The following is a description of a gene set: studied in species Homo sapiens Genes down-regulated in monocyte-derived dendritic cells: untreated versus LPS like antigen from O. planktothrix (1h). A cyanobacterial LPS antagonist prevents endotoxin shock and blocks sustained TLR4 stimulation required for cytokine expression. We report the identification and biologic characterization of an LPS-like molecule extracted from the cyanobacterium Oscillatoria Planktothrix FP1 (CyP). from publication Macagno A, Molteni M, Rinaldi A, Bertoni F, Lanzavecchia A, Rossetti C, Sallusto F (PMID 16717116) Human Gene Set: GSE4748_CTRL_VS_CYANOBACTERIUM_LPSLIKE_STIM_DC_1H_DN, and this is the list of marker genes: RIC8A (RIC8 guanine nucleotide exchange factor A), TXNIP, CCT6A (chaperonin containing TCP1 subunit 6A), ATF7, COL11A1, OPN4, SHOC2, SRPRB, SRSF10, RNF166, UBE2D3, TMEM106B, PDE1B, ATP6V0A1 (ATPase H+ transporting V0 subunit a1), ULK2, FER, GPR37, DMAP1, HTT, PAXBP1, FGF2, IGHG1, MAP3K2, SGTB, MGAT4B, ACTRT2, KATNBL1, GALNT11, CRTC2, PTGS1, SRSF5, SLC6A8, NEK1, TMEM38A, KIRREL1, SLC30A1, TFPT, PEX14, CDK18, CCNG1, CPE, NFATC4, PRP4K, PRKACA, SERPINE1, HSDL2, GFI1B, RIMKLB, TSNAXIP1, RNF144A, LRRC8C, SRFBP1, CD36, PC, TSGA13, TPBG, KCNQ1, ACTR2, HOXB7, NUP210, BRAF, MYO7A, SLC38A4, E2F4, PKHD1, RP2, COL6A2, ACBD3, CAPN7, TDP1, SNAI1, PLXNA1, AP3B2, DR1, FGFRL1, MIB1, CMPK1, DLX5, ST8SIA2, SC5D, EVPL, THOC2, PAPOLA, RGS8, TPT1, SLC2A9, KANK3, SNAPIN, FAM193B, ZNF346, PPP1R1B, TSPAN13 (NCBI Gene Id 27075), CTSC, FNBP4, TEAD4, TEAD1, MTSS1, DENND6A, PNPLA2, SP3, RICTOR, HOXC5, COPG1, DENR, SRSF1, SGMS1, SLC7A4, VEGFA, PRCP, ATG7, PCDH1, AP3M2, LMAN2, CAPZA3, XPO1, COL13A1, ZMIZ1, FABP4, SLC25A22, CDX2, CLDN6, PHKA2, BBLN, WDR1, LENG8, SCML2, MTARC1, TOM1L2, DCLRE1A, MMP13, ATRN, MTMR6, NR4A1, HADHA, PLAT, PTEN (NCBI Gene Id 8037), LXN, NHSL3, ORMDL3, SYT13, HOXB1, PITPNB, YWHAE, FANCA, SLC25A24, RASAL1, CSTF2 (NCBI Gene Id 1478), FAM50B, LIMS4, ATP2C1, CRX, RAD54L2, SFT2D2, RNF19B, CHRNA7, IL12RB1, ITGA2, ERO1A, MYLK2, JAG1, NUDT4, LTO1, HSD17B7, DAO, UGT8, CDKAL1, MMP19, MSN, AP1G1, SNN, TOR1AIP2, TRAK1, CYTH2, GHRL (NCBI Gene Id 51738), PLIN2, NSD1, FYCO1, TMPO, SPP1, FBXO22, IKZF2, TRPM1, SEPTIN6, METTL25B (methyltransferase like 25B), CBS, SMAD6, ADCY7, CYP2F1, ANGPTL4, ADAMTSL4, GBP6, FOXK1, MEG3, PARP1, LIG3, PARM1, PTBP1, WASHC4, LAT